Given this list of marker genes Ccl4, Slc16a3, Agpat4, Nr4a1, Pde4b, Cd14, Btg1 (BTG anti-proliferation factor 1), Zfas1, AW112010, Rasgef1b, 2410006H16Rik, Ccl5, Nfil3, Bhlhe40, H2-Eb1, Sp140, Ccrl2, Tiparp, Cxcl16, Inmt, Id3, Pcolce2, Nfe2l2, Ifitm2, Ifrd1, Jund (jun D proto-oncogene), Cd52, Il1b, Ccnl1, Pim1, Snx20, Cd83, Ins2 (NCBI Gene Id 16334), Krt15, H2-Aa, H2bc4, Junb, Ifi30, Cd74, H2-Ab1, Rilpl2, Cd207, Fosl2, here is a description of the gene set: studied in species Mus musculus Mouse Gene Set: TABULA_MURIS_SENIS_LIVER_MYELOID_LEUKOCYTE_AGEING from publication Tabula Muris Consortium (PMID 32669714)